The following is a description of a gene set: studied in species Mus musculus Mouse Gene Set: GOCC_MITOCHONDRIAL_2FE_2S_ASSEMBLY_COMPLEX A protein complex capable of forming 2Fe-2S clusters in mitochondria. In humans it consists of ISCU, NFS1, LYRM4, NDUFAB1 and FXN., and this is the list of marker genes: Fxn, Ndufab1, Nfs1, Lyrm4 (NCBI Gene Id 380840), Iscu